Given this list of marker genes CCNB1, TPR, AAAS, POM121, NEK6 (NCBI Gene Id 58167), NUP107, NUP43, NUP35, NUP153, NUP210, NUP62, NUP160, POM121C, CCNB2, RAE1, NUP155 (NCBI Gene Id 9631), NUP98, NUP58, NUP37, NUP85, NUP93 (NCBI Gene Id 9688), NUP214, CDK1, SEH1L, NUP42 (nucleoporin 42), SEC13, NUP133, NUP50, NDC1, NUP205, NUP88, NEK7, NUP188, RANBP2, NUP54 (nucleoporin 54), NEK9, here is a description of the gene set: Human Gene Set: REACTOME_NUCLEAR_PORE_COMPLEX_NPC_DISASSEMBLY studied in species Homo sapiens Nuclear Pore Complex (NPC) Disassembly